Given this list of marker genes Rpl27a-ps2, Slitrk6, Gm19146, Gm9348, Gm24229, Gm18977, Gm26255, Slitrk1, Gm7313, Gm9334, Gm25901, Gm17932, Gm22823, Gm9335, here is a description of the gene set: species: Mus musculus Mouse Gene Set: chr14E3